Given this list of marker genes DYNC1H1, TUBA1A, NUDC, RELN, PAFAH1B2, CLIP1, PAFAH1B3, NDEL1, DCX, VLDLR (NCBI Gene Id 7436), PAFAH1B1, here is a description of the gene set: PAFAH1B1 copy number variation species: Homo sapiens Human Gene Set: WP_PAFAH1B1_COPY_NUMBER_VARIATION